The following is a description of a gene set: species: Homo sapiens Human Gene Set: HP_IMPULSIVITY Acting on the spur of the moment or on a momentary basis without consideration of outcomes; having difficulty establishing or following plans; experiencing a sense of urgency and engaging in behavior that is uninhibited, cannot be inhibited, and is uncontrolled. The possibility of repression is inconceivable. Impulsivity, and this is the list of marker genes: NTRK1, EIF4G1, PINK1, BCORL1, ADAT3, FBXW11, WDR62, MYT1L, YWHAG, CDK19, DLL1, NODAL, GABRB2, SYNGAP1, CACNA1B, EIF4A2, FGF12, VPS13C (vacuolar protein sorting 13 homolog C), ATP1A2, ACTL6B, SYNJ1, GRIN2D, VPS35, HEPHL1, FGF8, GLDC, SLC1A2, SRCAP, RAI1, GABRB3, SCN1A, AP3B2, DNM1, GABBR2, VANGL1, NAA20, AQP4, GRIN2A, TGIF1, FOXH1, STIL, SLC38A3, CACNA2D1, DNMT1, TSC1, NFIB, ATP1A3, USP7, FBXO28, KANSL1, SCN3A, H4C5 (H4 clustered histone 5), DEAF1, PRKN, AFF2, UBA5, WWOX, FZR1, GRIK2, FOXG1, CYFIP2, SLC1A3, PANK2, SPEN, HIVEP2, CDON, DISP1, HTRA2, SCN1B, ZIC2, SIX3, TRAK1 (NCBI Gene Id 22906), MAOA, SNCA, TMEM240, NTRK2, LGI1, PCDH19, GBA1, IFNG, MAPT, PPP3CA, UCHL1, SPTBN1, GIGYF2, DPYSL5, RELN, MAGEL2, AARS1, SCN9A, C19orf12, SZT2, PODXL, PARS2, EEF1A2, GCSH, PLA2G6, DNAJC6, SHH, DNAJC13, GLI2, KCNA2, KCNB1, NONO, NUS1, PHIP, GABRG2, GABRA5, ATP6V1A, CDH2, GNB2, AHDC1, IL1RAPL1, CREBBP, SLC13A5, TSC2, PTCHD1, TTI1, CELF2, KNL1, VPS16, PTCH1, PACS2, DEPDC5, LRRK2, EP300, CACNA1A, GAS1, IQSEC2, POLA1, DHDDS, ARPC4, PARK7, COQ5, SCN2A, SUGCT, SCN8A, CNKSR2, NECAP1, CEP152, UBTF, HCN1, CLTC, FUZ, KCNC2, GABRA1, DALRD3, CRIPTO, FLII, GABRA2